Given this list of marker genes AEBP1, B3GAT3, XYLT1, EXOC6B, COL1A1, RYR1, FLNB, SLC35A3, SLC35B2, HNRNPH1, IFT56, SLC10A7, BPNT2, SYNE1, CHST3, here is a description of the gene set: species: Homo sapiens Human Gene Set: HP_KNEE_DISLOCATION Knee dislocation